The following is a description of a gene set: Any process that stops, prevents or reduces the frequency, rate or extent of dendritic cell apoptotic process. Human Gene Set: GOBP_NEGATIVE_REGULATION_OF_DENDRITIC_CELL_APOPTOTIC_PROCESS species: Homo sapiens, and this is the list of marker genes: CXCL12, CCL19, CCL21, CCR7, AXL, BCL2L1, GAS6, LILRB1, BCL2